The following is a description of a gene set: studied in species Mus musculus from publication Chen Y, Wang X (PMID 31504780) Mouse Gene Set: MIR_342_5P Genes predicted to be targets of miRBase v22 microRNA mmu_miR_342_5p in miRDB v6.0 with MirTarget v4 prediction scores > 80 (high confidence targets)., and this is the list of marker genes: Mab21l2, Ppm1f, Ctnnbip1, Surf6, Phc1, Pramel32, Ppargc1a, Ralgps1, Pcyt2, Ino80d, B4galnt1, Pfn1, Dnajb5, Lrch1, Slc36a4, Mknk2, Dlg4, Nav2, Col5a1, Ccar2, Srd5a1, Cbx2, Mfap4, Nfix, Sorcs3, Atp6v0d2, Zfp574, Semp2l1, Tifab, Ehd1, Fdx1, Alpi, Fbxw11, Gm2a, Vcan, Pank1, Eeig1, Sypl2, Diras1, Vsx2, Cldn18 (NCBI Gene Id 56492), Mtrfr, Fam168a, Gprc5b